The following is a description of a gene set: Human Gene Set: MORF_PPP5C Neighborhood of PPP5C protein phosphatase 5, catalytic subunit in the MORF expression compendium Neighborhood of PPP5C species: Homo sapiens, and this is the list of marker genes: MUTYH, PDXDC1, TAF2, SLC25A11 (NCBI Gene Id 8402), NMT1, BRCA1, ZNF592, SPAST, KLHL18, PHF10, SIGMAR1, MSH3, TMEM11, CYP4F12, HNRNPL, OARD1, DIMT1, CCNF, CSTF3, GALNT2, SLC24A1, FNTB, GRIK5, ERAL1, BTD, ENTREP1, SH2B1, CHD3, HTR7, EP400, NFYB, RPS6KB2, SPRED2, PPP5C, NR2C1, PIGB (phosphatidylinositol glycan anchor biosynthesis class B), PIGF, MEA1, GSK3B, TRIM27, CPSF4, REV3L, PFDN6, RBBP8, FOXD1, IMPA1, NKRF, RAP1A, SYNJ2, FDXR, JRK, POP4, PAXIP1, BAHD1, CETN3, INPP5E, CLPX, EXTL3, PLEKHB1 (pleckstrin homology domain containing B1), TTI1, MC2R, UBE4B, AMFR, SLC30A3, KIAA0586, FANCI, ATP6V0A2, KLHDC10, PIK3R2 (NCBI Gene Id 5296), WDR62 (NCBI Gene Id 4181), FRYL, ERCC2, ILVBL, BPHL, ATRX, TMEM94, SCAMP1, KRT33A, PCGF1, FANCG, MFN1, NFRKB, MTX1, SSR1, EIF5B (eukaryotic translation initiation factor 5B), GRIP2, CLP1, CAMK2G, RFC5, ZNF500, CDK13